Given this list of marker genes Gm35183, Sorbs1 (NCBI Gene Id 75688), Armh3, Lgi1, Abcc2, Slc25a28, Gm8974, Arhgap19, Cuedc2, Cyp2c23, Borcs7, Lcor, Mir6405, 1700039E22Rik, Gbf1, Nt5c2, Dpcd, Calhm2, Psd, H1f11-ps, Cwf19l1, Tm9sf3, Marveld1, Scd2, Gm24610, Cyp2c40, 4833438C02Rik, Atp5mk (ATP synthase membrane subunit k), Gm36693, Pik3ap1, Taf5, Gm36602, Entpd7, Hoga1, Ankrd2, Cyp2c39, Gm35867, Tlx1, Cyp2c68, 4933411K16Rik, Cyp2c69, Scd1, Wbp1l, Gm19179, Cyp2c37, Sfrp5, Gm18379, Cyp2c29, Gm6937 (NCBI Gene Id 639215), Gm19437, Pkd2l1, Plce1, Pcgf6, Gm8717, Cyp2c72-ps, Cyp2c65, 1700016H03Rik, Calhm1, Crtac1, Gm5827, Frat2, Gm8783, Cutc, Calhm3, Ubtd1, Nolc1, Sec31b, Gm16027, 4930414N06Rik, Exosc1, R3hcc1l, 4930505N22Rik, Scd4, Pdcd11, Kazald1, Sfxn3, Gm6776, Ndufb8, Rrp12, Slk, Cyp2c70, Gm27042, Gm20467, Blnk, A930028N01Rik, Cyp2c50, Sh3pxd2a, Sufu, Sema4g, Nfkb2, Ccnj, Cc2d2b, Slit1, Pax2, Stn1, Tctn3, Slc35g1, Cyp2c55, Cyp2c71-ps, Golga7b, Gm16470, Poll, Gm9788, Btrc, Cyp2c53-ps, Pgam1, Zfyve27, 4933403J19Rik, Gm19557, Pdlim1, Gm6951, Kcnip2, Loxl4, Arl3, Wnt8b, BC037704, Scd3, Actr1a, Gm24400, Mir6995, Cox15 (cytochrome c oxidase assembly protein 15), Pprc1, Hps1, Gm5246, Tbc1d12, Gm26644, Pi4k2a, Gm34922, Noc3l, Zdhhc16, Gm6813, 2310034G01Rik, Gm46644, Gm5693, Oga, E030044B06Rik, Ina, Cnnm1, Lzts2, Mfsd13a, Pyroxd2, Neurl1a, Cyp17a1, Mir146b, Tll2, Gm34517, Sfxn2, Nkx2-3, Gm35460, Ldb1, Trim8, Gm24336, Cpn1, Mir8091, Chuk, Mir8092, Mms19, Mir3085, Aldh18a1, Mrpl43, Gm35610, Gm6807, Gm23113, Gm28578, Avpi1, Hpse2, Got1, Frat1, Gm15801, Morn4, Pitx3, Pdzd7, Gm6967 (NCBI Gene Id 629359), Gm25216, Dnmbp, Bloc1s2, Dntt, Fbxl15, Gm16244, Opalin, Zfp518a, Gm34299, Hells, As3mt, Npm3, Cyp2c52-ps, Cyp2c66, Gm25482, Mir5114, Lbx1, Entpd1, Cnnm2, Hps6, Gm18936, Cyp2c67, Slf2, Fgf8, Erlin1, Cyp2c54, Fbxw4, Hif1an, Cyp2c38, Gm35406, Twnk, Elovl3, here is a description of the gene set: Mouse Gene Set: chr19C3 species: Mus musculus